Given this list of marker genes FAHD2A, MTMR1, ARPC2, BRK1, ZNF518B, ABTB3, RABGAP1L, PBX1 (PBX homeobox 1), PAM (peptidylglycine alpha-amidating monooxygenase), PHACTR4, ORM2, ITGAL, PYGB, KRT84, FLT3LG, ATP6AP1, DESI1, SSR1, GMPPA, DOCK10, GFI1, KRT28, GATAD2A, INHBA, ACTN4, RASA2 (NCBI Gene Id 5922), ITGA4, TAB2, ITGAX, NCK2, CDS2, UBE2J1, ITPRIPL2, DNAJB13, STXBP1, ARAP3, SAMM50, TNFRSF1B, ATOSB, MAGEB5, NAT14, ALDH18A1, RIN2, TOLLIP, PRDM1, TEX2, SOCS2, TNFRSF1A, PLIN2, TRAPPC2L, TNFSF10, MAST2, REX1BD, CD38 (CD38 molecule), ZNF473, DDX19A, FRMD4B, HTR4, GAB2, PKIG, YIF1A, ZNF787, ANKRD40, RELB, NFIL3, GAS7, CAMKV, FPR1, RUNDC3B, TMEM47, DTNBP1, BLOC1S1, SMIM3, GTDC1, RAP2A, ATF6, FBXO41, FGFRL1 (fibroblast growth factor receptor like 1), CD82 (CD82 molecule), CRHR2, SEC16B, KLHL4, AGPAT2, DOP1B, BRAP, WWP1, USP47, MKNK2, PPM1J, THBD, RNF157, FAM229A, STING1, MYO6, PGLYRP1, SPTBN1, GPAA1, TECR, GIMAP5, FCGR2B, NRSN2, PIH1D1, PADI2, HMGA1, FZD6, RETSAT, PLSCR1, PDCD6IP, SORL1, F2RL2, HOXD9, PPP3CC, TMEM170B, UBA1, MTMR12, PDHA1, CDIN1, ATXN7L1, RAB14, PWWP2B, MGME1, AOAH, PPP4R1, ERLIN2, CARHSP1, AJM1, NRROS, CABLES2, GEM, NUDT12, UBP1, RNF10, SELENBP1, NAAA, TNFRSF18, C11orf24, TGFBRAP1, BHLHE40, RAPH1 (Ras association (RalGDS/AF-6) and pleckstrin homology domains 1), AKR1B10, NOL9, RELL1, ZNF287, MX1, SLC12A6, BIN3, GYG1, ARHGAP18, P2RY1 (NCBI Gene Id 90963), PRDX5, SLC2A8, RNF187, LAMP2 (NCBI Gene Id 3920), TDRD7, RAB3GAP2, TMEM150A, RAB37, TMUB1, CTNNA1, UBE2M, CHST11, DIAPH1, RABL3, GNAS, TCIRG1, CAP1, CKB, UNC93B1, ATP2A2, MACROH2A1, PPP1R37, KDM4D, ABCA8, QNG1, RPAP1, GNB1, SAMD10, MYO1E (NCBI Gene Id 4643), LRP10, RAP1GAP2, ABCA7, NR2F6, MARCHF6, SP7, TTF2, LIFR, FNBP1, TRAPPC1, EIF3C, MZB1, RRAGC, GPNMB, HNRNPA0 (NCBI Gene Id 10949), UBE2G2 (NCBI Gene Id 7327), MRPL51, GABARAPL1, MYH9, TFPI2, ADGRE5, TVP23A (trans-golgi network vesicle protein 23 homolog A), here is a description of the gene set: Genes down-regulated in comparison of CD8 T cells versus NKT cells. Each fraction of mouse hematopoietic cells was purified by cell sorting from bone marrow of 8-week-old C57BL/6 mice, and its gene expression was analyzed. from publication Konuma T, Nakamura S, Miyagi S, Negishi M, Chiba T, Oguro H, Yuan J, Mochizuki-Kashio M, Ichikawa H, Miyoshi H, Vidal M, Iwama A (PMID 21540074) studied in species Homo sapiens Human Gene Set: GSE27786_CD8_TCELL_VS_NKTCELL_DN